The following is a description of a gene set: Human Gene Set: ATGAAGG_MIR205 Genes having at least one occurence of the motif ATGAAGG in their 3' untranslated region. The motif represents putative target (that is, seed match) of human mature miRNA hsa-miR-205 (v7.1 miRBase). species: Homo sapiens, and this is the list of marker genes: CDH11, ADAT1, LPCAT1, BTBD3, CLTC, MED1, HSD17B11, INPPL1, MSL2, DSC1, SCMH1, LRRC37A6P, CDK19, SORBS1, TMEM260, SEL1L, ZNF800, VCF1, MMD, TRPM2, CLDN11, E2F1, SEMA4C, ETF1, ESRRG, KLF12, PAFAH1B1, PHC2, INHBA, ST6GALNAC3, DGCR8, NACC2, PTGES2, GANAB, AP1G1, PDE3B, ACTB, TBL1XR1, GTF3C2 (NCBI Gene Id 2976), MFSD14B, MGRN1, LRP1, KIF1B, SQLE, BCL2 (NCBI Gene Id 596), JPH4, RUNX2, NECAP1, GPM6A, MAGI1, VEGFA, DLG2, TP53INP1, RBPMS2, NFAT5, CHN1, LAMC1, FRK, PAPLN, PRKCE, TM9SF3 (transmembrane 9 superfamily member 3), PJA2, SEPTIN3, ERRFI1, DDX5, SEH1L, TRAK2, VASN, NAA25 (N-alpha-acetyltransferase 25, NatB auxiliary subunit), ATP7A, SMG7, DDX11, TEAD1, HS3ST1, SEPTIN4, SELENOT, ADAMTS9 (ADAM metallopeptidase with thrombospondin type 1 motif 9), ERBB3, DOK4, CCNJ, AMOT (NCBI Gene Id 23340), ACOT7, VPS54, LPAR1, PTPRM, B4GALT6, IVNS1ABP, VEZF1, CNIH1, SIAH1, ABHD17B, DMXL2, MARCKS, CDC42BPB (CDC42 binding protein kinase beta), WWC2, CALU, RBM47, ZNF609, QKI, PPP4R3A, SRSF10, TRIM35, ACACA, RTN3, LIMK1, RPS6KA3, LRATD2, PLCB1, MTMR4, PLAGL2, SEPTIN5, BPTF, ACSL1, SBF2, UBE2G1, SRSF5, PHYHIPL, CANX, MKNK1, ZCCHC14, MID1IP1, LIMS2, CUEDC2, UBE2N, FBXO24, SEPTIN11, DDX6, RLIG1, ZNF536, SLTM, CAMSAP2, EPB41, LIN9, TSC22D1, CCDC93, HERC4, WDR48, CEP192, LHFPL2, KHNYN, SATB2, IPO7, TRPS1, NALF2, SPEF1, SP4, LRRK2, NHS, DMXL1, DALRD3, CPEB2, GPATCH4, YES1, SGMS1, NDUFA4, SNX27, HERC3